Given this list of marker genes Dpp4, Piezo1, Cxcl13, Cd24a, Ada, Podxl, Cd3e, Wnk1, Swap70, Skap1, Fermt3, Ccl5, here is a description of the gene set: Any process that modulates the frequency, rate, or extent of cell-cell adhesion mediated by integrin. species: Mus musculus Mouse Gene Set: GOBP_REGULATION_OF_CELL_CELL_ADHESION_MEDIATED_BY_INTEGRIN